The following is a description of a gene set: species: Mus musculus Mouse Gene Set: GOBP_MESENCHYMAL_STEM_CELL_DIFFERENTIATION The process in which a relatively unspecialized cell acquires specialized features of a mesenchymal stem cell. A mesenchymal stem cell is a cell that retains the ability to divide and proliferate throughout life to provide progenitor cells that can differentiate into specialized mesenchymal cells., and this is the list of marker genes: Gsk3b, Ctnnb1, Sox5, Nr6a1, Mir154, Sox6, Pdgfra, Ltbp3, Wnt3 (NCBI Gene Id 22415), Ndufs6, Rest, Fzd1, Sox9, Slc4a11